Given this list of marker genes TP53INP1, ERBB2, CYP1A1, S1PR3, EFNB2, ZFP36L2, here is a description of the gene set: Transcriptional effects of estrogen result from its activation of two estrogen receptor (ER) isoforms; ERalpha that drives proliferation and ERbeta that is antiproliferative. Expression of ERbeta in xenograft tumors from the T47D breast cancer cell line reduces tumor growth and angiogenesis. If ERbeta can halt tumor growth, its introduction into cancers may be a novel therapeutic approach to the treatment of estrogen-responsive cancers. To assess the complete impact of ERbeta on transcription, we have made a full transcriptome analysis of ERalpha- and ERbeta-mediated gene regulation in T47D cell line with Tet-Off regulated ERbeta expression. Of the genes and transcripts analysed, 4.1% (1434) were altered by ERalpha activation. Tet withdrawal and subsequent ERbeta expression inhibited the ERalpha regulation of genes and, in addition, altered expression of 152 non-ERalpha-regulated genes. ERalpha-induced and ERbeta-repressed genes were involved in proliferation, steroid/xenobiotic metabolism and ion transport. The ERbeta repressive effect was further confirmed by proliferation assays, where ERbeta was shown to completely oppose the ERalpha-E2 induced proliferation. Additional analysis of ERbeta with a mutated DNA-binding domain revealed that this mutant, at least for a quantity of genes, antagonizes ERalpha even more strongly than ERbeta wt. From an examination of the genes regulated by ERalpha and ERbeta, we suggest that introduction of ERbeta may be an alternative therapeutic approach to the treatment of certain cancers. The 'ER-alpha profile': genes down-regulated in T47D cells (breast cancer, ESR2 Tet-Off) upon activation of ESR1 by estradiol (E2). from publication Williams C, Edvardsson K, Lewandowski SA, Ström A, Gustafsson JA (PMID 17700529) species: Homo sapiens Human Gene Set: WILLIAMS_ESR1_TARGETS_DN